The following is a description of a gene set: species: Homo sapiens Human Gene Set: HP_UVEAL_MELANOMA A malignant melanoma originating within the eye. The tumor originates from the melanocytes in the uvea (which comprises the iris, ciliary body, and choroid). Uveal melanoma, and this is the list of marker genes: GNA11, STK11, GNAQ (NCBI Gene Id 2776), CYSLTR2, BAP1, SF3B1, MBD4, BRAF